Given this list of marker genes PLD1, FBLN5, AR, EFEMP2, MAMLD1, LTBP1, here is a description of the gene set: Urethral diverticulum Human Gene Set: HP_URETHRAL_DIVERTICULUM species: Homo sapiens The presence of a diverticulum (sac or pouch) in the wall of the urethra.